Given this list of marker genes TRAF6, MAVS, IKBKE, TBK1, TRAF3, IFNB1, RIGI, IRF3, TOMM70, here is a description of the gene set: studied in species Homo sapiens Human Gene Set: WP_SARSCOV2_B117_VARIANT_ANTAGONISES_INNATE_IMMUNE_ACTIVATION SARS-CoV-2 B.1.1.7 variant antagonises innate immune activation